Given this list of marker genes CRYL1, AKR1A1, XYLB, DCXR, SORD, here is a description of the gene set: Human Gene Set: GOBP_D_GLUCURONATE_CATABOLIC_PROCESS_TO_D_XYLULOSE_5_PHOSPHATE studied in species Homo sapiens The chemical reactions and pathways resulting in the breakdown of D-glucuronate into D-xylulose 5-phosphate.